The following is a description of a gene set: species: Mus musculus Mouse Gene Set: GOCC_GINS_COMPLEX A heterotetrameric protein complex that associates with replication origins, where it is required for the initiation of DNA replication, and with replication forks., and this is the list of marker genes: Gins3, Gins2, Gins4, Gins1, Slc5a8